The following is a description of a gene set: The somatic process that results in the generation of sequence diversity of immunoglobulins. studied in species Homo sapiens Human Gene Set: GOBP_SOMATIC_DIVERSIFICATION_OF_IMMUNOGLOBULINS, and this is the list of marker genes: EXO1, ATAD5, SLC15A4, PAXIP1, SHLD3, TP53BP1, TCF3, HSPD1, XRCC4, NFKBIZ, CCR6, POLL, ERCC1, MAD2L2, CTNNBL1, STAT6, IL4, HMCES, NHEJ1 (non-homologous end joining factor 1), RNF8, BCL6, NBN, APLF, TBX21, LIG4, MSH3, KMT5B, IL27RA, TGFB1, NSD2, SAMHD1, FOXP3, CD28, TFRC, PARP3, POLB, POLQ, SHLD1, BATF, CD40LG, TNFSF4, PCYT1A, CYREN, PRKDC, SUPT6H, KMT5C, SHLD2, SANBR, EXOSC6, PMS2, RIF1, UNG, MCM3AP, PTPRC, AICDA, RNF168, MLH1, POLM, TNFSF13, YY1, MSH6, CD40, CLCF1, MSH2, IL10, IL2, EXOSC3, SWAP70, NDFIP1